The following is a description of a gene set: studied in species Mus musculus Catalysis of the reaction: a very long-chain fatty acid + ATP + CoA = a very long-chain fatty acyl-CoA + AMP + diphosphate. A very long-chain fatty acid has an aliphatic tail containing more than 22 carbons. Mouse Gene Set: GOMF_VERY_LONG_CHAIN_FATTY_ACID_COA_LIGASE_ACTIVITY, and this is the list of marker genes: Slc27a2, Slc27a5, Slc27a4, Slc27a6, Acsf3, Acsbg1, Slc27a3, Slc27a1, Acsl4 (acyl-CoA synthetase long-chain family member 4)